Given this list of marker genes ATP5MC3, ATP5MC2 (ATP synthase membrane subunit c locus 2), MT-ATP8, ATP5F1B, ATP5MJ, ATP5F1A, MT-ATP6, ATP5MK, ATP5PD, ATP5F1E, ATP5MF, ATP5MC1, ATP5ME, ATP5PO, ATP5MG, ATP5PF, ATP5F1C, DMAC2L, ATP5PB, ATP5F1D, here is a description of the gene set: Reactome Pathway: Formation of ATP by chemiosmotic coupling species: Homo sapiens The re-entry of protons into the mitochondrial matrix through Complex V causes conformational changes which result in ATP synthesis. Complex V (ATP synthase) is composed of 3 parts; an F1 catalytic core (approx 5 subunits), an F0 membrane proton channel (approx 9 subunits) and two stalks linking F1 to F0. F1 contains three alpha subunits, three beta subunits, and one each of gamma, delta, and epsilon subunits. Each beta subunit contains an active site for ATP synthesis. F0 has at least 9 subunits (a-g, A6L and F6; see Lai et al., 2023; reviewed in Jonckheere et al., 2011).<br>The mechanism of ATP synthesis by Complex V was predicted by Boyer et al in 1973: ADP and Pi bind to the enzyme resulting in a conformational change. ATP is then synthesized, still bound to the enzyme. Another change in the active site results in the release of free ATP into the matrix. The overall reaction is:<br>ADP + Pi + H+ + nH+ (intermemb. space) = ATP + H2O + nH+ (matrix)<br><br>Mutations in several ATP synthase subunits can lead to different types of mitochondrial complex V deficiency (MC5D; reviewed in Garone et al., 2022; Del Dotto et al., 2024). part of: Aerobic respiration and respiratory electron transport